The following is a description of a gene set: species: Homo sapiens from publication Lisiero DN, Soto H, Liau LM, Prins RM (PMID 21430221) The expansion, trafficking and functional effectiveness of adoptively transferred CD8+ T-cells play a critical role in mediating effective anti-tumor immunity. However, the mechanisms which program the highly proliferative and functional state of CD8+ T-cells are not completely understood. We hypothesized that IL-12, a cytokine commonly induced by TLR activation, could enhance T-cell priming by altering responsiveness to antigen and cytokines. Priming of tumor specific CD8+ T-cells in the presence of IL-12 induced the acquisition of a 'polyfunctional' effector response and increased the generation of memory cells. Moreover, IL-12 priming also promoted high levels of the IL-2 receptor alpha-chain (CD25) and robust IL-2 mediated activation of STAT5. This sensitivity to IL-2 translated into enhanced in vivo proliferation of adoptively transferred CD8+ T-cells. Furthermore, real-time, in vivo imaging of T-cell trafficking confirmed the ability of IL-12 priming to drive in vivo proliferation. IL-12 priming enhanced the anti-tumor function of adoptively transferred cells by reducing established subcutaneous tumor burden, and significantly increasing survival in an established intracranial tumor model. Finally, IL-12 priming of human PBMCs generates tumor specific T-cells phenotypically and functionally similar to IL-12 primed Pmel-1 T-cells. These results highlight IL-12 as an important mediator of CD8+ T-cell effector function and anti-tumor immunity. Genes down-regulated in Pmel-1 CD8 T cells: naïve versus primed with cognate antigen (gp100) and IL-12. Human Gene Set: GSE22443_NAIVE_VS_ACT_AND_IL12_TREATED_CD8_TCELL_DN, and this is the list of marker genes: AGPS, GABARAPL1, SGTA, EXOSC8, MED7, LYPLA2, CLTC, CAPN9, C3orf22, AMMECR1L, ST18, PCDHB3, DDX39A, CCDC32, EIF2B3, XPNPEP3, TMEM97, CYP2C8, XYLB, RBL1, BCAP29, MAB21L3, MRAS (NCBI Gene Id 654181), PAPPA2, C21orf91, PCCB, TMED5, DISP1, KIF5B, NUPR2, VWC2, RPN1, B4GALT7, ST13, TNFAIP6, EIF3B, RBM25, CDK9, IL12RB1, MMP3, APPBP2, SBDS, GCAT, KRT4 (NCBI Gene Id 3851), FAM120C, RHBDL2, C2orf88, ATF3, MYORG, SPART (NCBI Gene Id 23111), SGK1, LRRC59, NEU2, GCNT2, CYP7A1, CEP128, DDX20 (NCBI Gene Id 51452), CYP4A11, UMODL1, PSEN1 (presenilin 1), TMEM161B, GALNTL5, NDUFAF8 (NCBI Gene Id 284184), SEC24D, DOP1A, CCNO, OAZ2, CLASP1, EIF4A1, PDE4D, NUDT3, RIPOR2, MRPS30, AVEN, GHSR, WNT5A, TIPRL, MAPRE1, MYO3B, PIGH, CMTR1, SIPA1L1, ACAD8, OR4E2, TAF1B, SSPN, ERP27, PRKACA, YTHDF2, ATXN1, PAFAH1B1, IL10, DNAJC12, NEURL1, SPEN-AS1, HDHD3, SLX4IP, BDP1, GTF2H1, EGLN3, CUL3, NAA50, GTF2F2, PAK1IP1, RAB1A, SYT12, RTL5, POLR3A, TMEM181, MORC2, CLP1, TMEM248, RPAP3, CGAS (NCBI Gene Id 115004), FSCN3, RGS13, TRIM66, LCOR, USP37, EIF2B5, HNRNPM, TOX3, DCAF17, ANKRD34A, CARNMT1, CLIC4, ACTC1, TRAT1, CHIC2, GNGT1, U2SURP, FAM53B, PKD2L2, ALS2, NDUFA12, WDR45B, ATP1B3, DCTN5, DNAJB4, CCDC171, CEP57L1, CERCAM, QRICH1, KIRREL3, ZNF18 (NCBI Gene Id 7566), PPP2R5E, PGM5, RGMA, DACH1, ELN, ASNS, DRGX, CHCHD2, APIP (APAF1 interacting protein), IL1RL1, NUCB1, LYRM9, SHCBP1L, ALG14, MDH2, XIST, COQ3, TAL1, NUDCD1, TOP3B, BCAS1, ZCCHC2, AGO3, TAF9, CSMD1, RALYL, ABCC3, PLAG1, DNAJC24, NUP43, SERPINB11, MFSD12, P2RY14, VWA3A, PTPRM, IMP4, GUCY2C, ACER2, ALX1, SDR42E1, KCNE3, TRIO, SRRM1, BTD, GNPDA2, CENPU, EEPD1, LINC00301, BDKRB2, BICD2, SLC1A4, CLVS2, CD80, GRPEL1, CKAP2L